The following is a description of a gene set: Human Gene Set: WP_GASTRIC_CANCER_NETWORK_2 species: Homo sapiens Gastric cancer network 2, and this is the list of marker genes: DSCC1, TOP2A, CTNNB1, MIRLET7E, CHTF8, LMNB2, TP53 (NCBI Gene Id 7157), CACYBP, AHCTF1, COL9A3, RFC3, CEBPZ, UBE2T, OTUD5, FANCI, MTDH, UBE2C, RAD17, S100A6, RFC4, FAM91A1, RNF144B, EGFR, MYC, ATAD2 (NCBI Gene Id 84325), CD48, BRIX1, PLAC8, COL9A1, SNURF, LBR, CHTF18